The following is a description of a gene set: Human Gene Set: CUI_DEVELOPING_HEART_C6_EPICARDIAL_CELL from publication Cui Y, Zheng Y, Liu X, Yan L, Fan X, Yong J, Hu Y, Dong J, Li Q, Wu X, Gao S, Li J, Wen L, Qiao J, Tang F (PMID 30759401) species: Homo sapiens, and this is the list of marker genes: BCO2, NPNT, CLIC3, KRT18, KLK5, CARNS1, SELENBP1, HAS1, VGLL3 (NCBI Gene Id 51159), EPHB6, NNMT, RARRES1, MYRF, SAT1, SMTNL2, CD200, SLC16A1, LINC01133, MSLN, PAPSS2, PLEKHH2, HSD17B6, PRKCI, CRLS1, SMOC2, KRT19, PRSS23, CYBRD1, PTGIS, TIMP1, IL6ST, ITLN1, AQP1, ALDH1A2, MAL2, STEAP1, AOX1, SPOCK2, NUPR1, PCOLCE2, CLDN1, MST1, PHGDH, FKBP11, ID4, RASSF7, IL1R1, TM4SF1, KDR, TMEM176A, CDON, ADGRD1, PTPRQ, BNC1, CLDN15, LINC00842, EZR (NCBI Gene Id 7430), GJA1, MT1E, MUC16 (mucin 16, cell surface associated), GPM6A (NCBI Gene Id 2823), MEST, DAPK1, PLAAT4, TMEM37, TMEM176B, CFI, ALOX15, ASS1, KLF6, UPK3B, PKHD1L1, SLIT3, NFKBIZ, CPA4, SULF2, CRIM1, ADIRF, PDGFRL, SYT4, PLAAT3, FKBP2, PCLO, HP, PDPN, RERG (NCBI Gene Id 85004), CARD16, WT1, UPK1B, PRR15, TOR1AIP2, CYSTM1, CCDC80, PDGFC, FLRT3, LRP2, HCFC1R1, CA9, HLA-C, NHERF1, SULF1, LY6E, PROS1, SCG5, CXADR, CFH, SBSPON, SEZ6L2, LRRN4, ANXA3, OAT, TNNT1, SILC1 (sciatic injury induced lincRNA upregulator of SOX11), SLC39A8, CPE, IL18, S100A6, ARID5B, DDR1, SLC4A4 (NCBI Gene Id 8716), TNFRSF1A, CDH3, PDIA2, PLOD2, KRT7, PHYHIP, C1R, LGALS2, INMT, SLPI, ECRG4, GSTM3, SERPING1, PRG4, FLRT2 (NCBI Gene Id 9822), TMEM98, BCHE, PTPRF, HTRA1, C3, SEMA3C, MEDAG (NCBI Gene Id 84935), CFB, CHAC1, PRR15L, WWC1, SMPD3, RSRP1, BICC1, CLIP4, RARRES2, PLA2G2A, HSBP1L1, ANXA4, VSIR, CALB2, PDZK1IP1, TGM1, KRT8, S100A10, SGK1, ST3GAL5, REC8, LGALS3BP, MGST1, PROCR, C1S (NCBI Gene Id 716), PTGS1, VTN, PPL, REEP1, PTK2B, NMU, ZFP36L1, BICDL1, ITGA3, RNASE4, CRIP1, GFPT2, COLEC12, EFEMP1, ITGB8, CARHSP1, TOGARAM2, IQCA1, CGN, SEMA3B, ANXA8L1, KLK11, PLEKHA4, PLLP, TSPAN3, COBLL1, TCEAL2, NSG1